Given this list of marker genes SNRPF, CLNS1A (NCBI Gene Id 1207), SNRPD3, SNRPD2, SNRPD1, SNRPE, here is a description of the gene set: species: Homo sapiens Human Gene Set: GOCC_PICLN_SM_PROTEIN_COMPLEX A protein complex that contains pICln (CLNS1A) and several Sm proteins, including SmD1, SmD2, SmE, SmF, and SmG.